Given this list of marker genes Dtnbp1, Dnm3, Nlgn1 (neuroligin 1), Ube3a, Ngef, Efna1, Pten, Nlgn3, here is a description of the gene set: species: Mus musculus Mouse Gene Set: GOBP_NEGATIVE_REGULATION_OF_DENDRITIC_SPINE_MORPHOGENESIS Any process that decreases the rate, frequency, or extent of dendritic spine morphogenesis, the process in which the anatomical structures of a dendritic spine are generated and organized. A dendritic spine is a protrusion from a dendrite and a specialized subcellular compartment involved in synaptic transmission.